Given this list of marker genes MAPK3, ARNT, SYT10, ARNT2, RBFOX3, MAGED1, CDK5R1, CDK5, FOS, BDNF, PLK2, NAMPT, BMAL1, INS, MDM2, XPO1, GEM, MAPK1, IQSEC3, RET, NPAS4, CREBBP, here is a description of the gene set: NPAS4 regulates expression of target genes species: Homo sapiens Human Gene Set: REACTOME_NPAS4_REGULATES_EXPRESSION_OF_TARGET_GENES